The following is a description of a gene set: Human Gene Set: GOBP_NEGATIVE_REGULATION_OF_AUTOPHAGOSOME_MATURATION studied in species Homo sapiens Any process that stops, prevents or reduces the frequency, rate or extent of autophagosome maturation., and this is the list of marker genes: RUBCN, TMEM39A (transmembrane protein 39A), PHF23, UBQLN4, CLEC16A